The following is a description of a gene set: Human Gene Set: HP_HYPOMETHIONINEMIA Hypomethioninemia A decreased concentration of methionine in the blood. studied in species Homo sapiens, and this is the list of marker genes: LMBRD1, MMADHC, MTHFR, PRDX1, MTRR, MMACHC, MTR, ABCD4